The following is a description of a gene set: Human Gene Set: HP_HYPERTROPHIC_CARDIOMYOPATHY Hypertrophic cardiomyopathy Hypertrophic cardiomyopathy (HCM) is defined by the presence of increased ventricular wall thickness or mass in the absence of loading conditions (hypertension, valve disease) sufficient to cause the observed abnormality. species: Homo sapiens, and this is the list of marker genes: FANCD2, ACAD9, TGFB1, UBE3C, CAVIN1, SOS2, CSRP3, GNPTAB, GTF2IRD1, TXNRD2, YARS2, MT-ND3, NDUFAF8, SHMT2, ERCC4, NDUFB7, PPARG, RAF1, NDUFS4, NDUFAF4, TNNI3, LAMP2, BAZ1B, KIF20A, MRPL3, NDUFS8, NDUFS6, ATP5F1E, CRLS1, MYL2, PMM2, MEG3, QRSL1, NDUFA6, HRAS, MT-TN, GATA4, NDUFB3, FANCM, FKBP6, MT-TH, IFIH1, COX14, NDUFB11, MICOS13 (NCBI Gene Id 125988), NDUFB10, NDUFS1, MYPN, TTR, TMEM270, AIP, KRAS, FANCE, BAG3, RRAS, MRPS14, LIAS, SDHA, SAMHD1, SYNE1, COX15, FANCA, SMC1A, BRIP1, TRMT5, TMEM70, TIMMDC1, RRAS2, FASTKD2, ATPAF2, MAD2L2, SDHB (succinate dehydrogenase complex iron sulfur subunit B), METTL27, LMNA, HADH, MRAP, ABCC8, ACADVL, UQCRFS1, BSCL2, NDUFA11, GTF2I, SUCLG1, PRKAG2, RNU7-1, PPP1R21, MT-TS2, NEK8, TNNC1, EIF4H, LZTR1, SARDH, VCL, PYGM, KCNJ8, MT-CO3, NDUFAF1, TCAP, NFS1, FANCC, MRPL44, NDUFS3, MYBPC3, NAGLU, NDUFB9 (NCBI Gene Id 4715), NUBPL, KLHL24, BRCA1, BOLA3, HADHA, HGSNAT, VPS37D, MT-ND6, STX1A, MT-TF (mitochondrially encoded tRNA-Phe (UUU/C)), VARS2, NAGA, NDUFV1, COQ4, SOS1, RNASEH2A, NNT, OPA1, SLC30A10, SCO2, FANCB, UBE2T, SYNE2, MT-TK, NRAS, SHOC2, MYH6, LIMK1, RASA2, STAR, CLIP2, MRPL39, BCS1L, PPP1CB, COA5, MT-TQ, SUFU, SDHD, TNNT2, FOXRED1, PALB2, ELAC2, NF1, GTPBP3, INSR, TPI1, MAP2K1, PTPN11, HCCS, TTPA, BUD23, TSFM, RAD51C, VPS33A, MTO1, HSD17B10, NEXN, MT-TV, NDUFAF2, MT-CO2, ELN, FANCG, FTO, NDUFAF3, ATP5MK, PLN, DHCR7, LSM11, SLX4, MC2R, RIT1, RFWD3, ECHS1 (NCBI Gene Id 1892, enoyl-CoA hydratase, short chain 1), GAA, MT-CO1, CPT1A, TMEM126A, MT-ND5, FXN, UCP2, ANKS6, FHL1, RNASEH2C, NDUFA2, ABCC9, MIPEP, SLC25A4, FLNC, MRPS22, MT-ATP8, ALPK3, DNAJB4 (NCBI Gene Id 11080), ADAR, FANCL, CRYAB, ACTC1, NDUFA10, CAV3, AARS2, NCF1, SPRED2, ATP5F1D, COA6, PYGL, GLB1, TREX1, GLA, PRUNE1, MAP2K2, RNASEH2B, MRAS, BRAF, MYL3, RAD51, JPH2, MT-TL1, SLC22A5, MT-ND4, FHOD3, FANCI, RTL1, NDUFAF5, MEN1 (menin 1), RFC2, DLK1, SURF1, COX7B, SLC25A3, FBXL4, COQ2, GTF2IRD2, MT-ND2, SLC2A10, LRP12, FOS, CBL, DNAJC30, FNIP1, KLF1, ATP6V1A, DLD (dihydrolipoamide dehydrogenase), TAFAZZIN, ACTN2, SDHAF1, AGPAT2, DES, NDUFA1, LRPPRC, AGK, CAV1, NDUFS7, CLN3, FANCF, FAH, SGSH, MT-ND1, EMD, NDUFS2, PPA2, TTN, TAPT1, BRCA2, ATP5F1A, TULP3 (TUB like protein 3), XRCC2, NDUFV2, TANGO2, TMEM43, GNS, TKFC, KCNJ11, MYLK2, MYOZ2, COX6B1, COA8, MYH7 (myosin heavy chain 7), TPM1, MT-ATP6, CAPNS1, GPR101, MT-TW, ADSS1, TMEM126B, ATAD3A, TBL2